The following is a description of a gene set: studied in species Homo sapiens Genes having at least one occurrence of the motif KNNKNNTYGCGTGCMS in the regions spanning 4 kb centered on their transcription starting sites. This matches the AHR transcription factor binding site V$AHRARNT_01 (v7.4 TRANSFAC). Human Gene Set: AHRARNT_01, and this is the list of marker genes: LHX1, GRM7 (glutamate metabotropic receptor 7), CEMIP, MAGED2, ANKS1A (ankyrin repeat and sterile alpha motif domain containing 1A), CREBZF, AJUBA, TNPO3, GNAO1, AGFG2, GTF2A1, MXI1 (MAX interactor 1, dimerization protein), ID4, SYT12, KAZALD1, USO1, SRRM2, DCHS1, SOAT1, EPB41L4B, NR4A1, PTF1A, PAGR1 (PAXIP1 associated glutamate rich protein 1), NR3C1, MARCKSL1, NLGN3, BDNF, GSX1, WNT4, LUC7L3, NEUROD2, NIPBL, TACC1, MBNL1, ATOH1 (atonal bHLH transcription factor 1), ELK3, NAGLU, CKS1B, PAX2, TPI1P2 (triosephosphate isomerase 1 pseudogene 2), JAG1, BHLHE41, CRH (corticotropin releasing hormone), CNTNAP1, HPCAL1, GHR, FBXL20, PAX6, MAEA, PCDH17, STC2, FANCB, WFIKKN2, MOV10, KLF10, DTX1, ELAVL4, SESN2, RUNX1, NEUROG2, SOBP, RGS8, REPIN1, TRIM23, SOX4, ZEB2, INSM1, MEMO1, PPRC1, USP1, FOXD3, PTCHD4, CCR10, GABRA1, TAF11, MEX3B, CCN2, C8orf82, UGGT1, SGK1, CNNM1, EIF4A2, ADAM9, WSB1 (NCBI Gene Id 26118), VEZF1, SPEN, TGFB1, PHF1, SLITRK1, BCL11A, HOXB9, PITPNC1, ZBTB8A, CDK6, PABPC1, JAZF1, H2AZ1, PCDH1 (NCBI Gene Id 5097), ZBTB20, CAMK2D (NCBI Gene Id 817), PHPT1, STAM, ACSL4, HOXA5 (homeobox A5), RBM6, ONECUT2, TM2D2, TFAP4, HK2, RBBP7, SEZ6, DLL4, KLF15, TCF7L2, XPO6, BRSK1, EGR3, IP6K2, ELAVL2, CYP26B1, ZMYM2, CCDC177, RARG, ABTB2, SHC1, OPA3, DMC1, SPOCK2, HELZ2, RGS6 (regulator of G protein signaling 6), C12orf57, MMP1, PHF21A, ATXN7L2, MOSPD2, IL7, TMEM53, HES1, HECTD1, PDP1, TNKS2, PDGFB (NCBI Gene Id 5155)